Given this list of marker genes Fos, Arhgdib, Crip2, Mylk (NCBI Gene Id 68242), Cav2, Tk1, Syt10, H2bc23, Dgka, Arhgap9, Atp1a2, Man1a, Cd93, Gm22883, Nanp, Aass, Zfp970, Fgfbp1, Swt1, Esam, Trbj2-1, Cpt1a, Chd5, Slc30a1, Npr3, Pag1, Cavin2, Fes, A930012L18Rik (RIKEN cDNA A930012L18 gene), Cep290, Cd300e, Gja5, Cdca3, Tmem150a, Rbbp4, Aplnr, Tbx5, Ankra2, Tln1, Gimap6, Tmem25, Arhgap6, Arap3, Elovl4, Itga4, Slc12a4, Alox12, Hspa1b, Gja1, Svep1, Rbm3, Cadps, Rest, Gm4609, Slamf7, Adam15, Cldn18, Ace2, Casp1, Spred3, Slamf1, Ttc39c, Mab21l4, Rtp3, Pik3c2g, Dll3, 1500004A13Rik, Lamb2, Cyth4 (NCBI Gene Id 72318), Trav6n-6, Sfxn3, Cacna2d2, Gm11787, Zcchc24, Pla2r1, Zik1, Panx1, Atp8a2, Adra1a, Cd27, Trgj2, H2-T24, Gm10687, Gm3005, Sypl1, Stmp1 (NCBI Gene Id 67705), Hadh, Osbpl5, Pde5a, Eldr, Srpx2, Cnpy1, Hmcn1, Pi4k2b, Gm11651, Scube2, Col4a3, Gm12250, ENSMUSG00000122616, Gm22520, Gm3364, 4930403O15Rik, Mir378d, Efcc1, Ppm1e, Eps8l1 (EPS8-like 1), Pde3a, Acoxl, Kif1c, Ntng2, Foxa1, Fgf7, Slc2a3, Fgf12, Pax5, Tubb4a, Mmrn2, Inpp5k, Traf4, Hkdc1, Ptgfr, Maco1, Ccar1, Maml2, Abhd1, Rnf157, Slurp1, Id4, Ehd2, Zfp809, Fez2, Ago4, Cntln, Txk, Cnn2, Tmem116, Il4ra (interleukin 4 receptor, alpha), Upk1b, Tmt1a3, Ms4a6c, Hbb-bt, Fam162b, Pld2, Med9os, Ephb4, Lef1, Rasgrp2, Ephx1, Phldb2, Plxdc2, Snord16a, Tnfaip8l1, Sorbs3, 2610028H24Rik, Slc9a4, Itgax, Cecr2, Nat8f6, Pxdc1, Dhdh, Gprin3, Ptprc, Adamts1, Radx, Cbx3-ps6, Ptprb, Myo1d, Gm15675, Hecw2, Ahr, Clba1, Anks1, Rassf8, H4c16, Slamf6, Scn3a, Tmem204, Cxxc4, Fndc10 (fibronectin type III domain containing 10), Klrb1b, Esco2, Clec4a1, Trbj1-2, Angptl2, Hilpda, Il17re, Shd, Rhoj, Fbln5, Pagr1a, Trpc6, Huwe1, Sri, Cxcr2, Ctso, Blk, Epha1, Pcolce, Ccnd3, Arhgap30, Yap1, Aldh2, Snhg4, Csf1r, Ddr2, Irf8, Dock2, Drd2, Pard6b, Tob1, Gata3, Ushbp1, Actl6b, Cd84, Homer2, Wnk3, Gm10566, Prodh, Scimp, Spi1, Ube2s, Gm23247, Cd80, Tcim, Lxn, Gm3298, Gm1968 (NCBI Gene Id 328657), Scnn1b, Hlx, Itgb1bp2, Rgs18, Cer1, Mettl24, C1qtnf2, Sptbn1, Cyp4f15, Il7r, Tagln, Lamb1, Phospho1, Stmn3, 5430416N02Rik, Rasal3, P2ry14, Fam114a1, Ift57, Ppa1, Ifitm3, Rasl12, Nexn, Kank4, Edn1, Prkci, Myo10, Cmpk2, Poglut3, Ostf1, Mitf (NCBI Gene Id 17342), Epas1, Rftn2, Mt2, Fryl, Gm7551, Gm23406, Arhgap8, Mill2 (NCBI Gene Id 243864), Wls, Tmem200b (transmembrane protein 200B), Stab1, Tspyl4, Cacnb4, Flrt1, Fen1, Gulp1, Ager, Aqp4 (aquaporin 4), Amotl2, Mcm8, Nqo2 (NCBI Gene Id 18105), Arhgap27os3, Abca9, Adam22, Faf1, Syngap1 (synaptic Ras GTPase activating protein 1 homolog (rat)), Slc16a9, Mir181a-1hg, Vav1, Gm336, Dipk2b, Itpkb, Tcf7, Ar, Gm10258, Nrgn, Rnase4, Itpripl2, Acss1, Atp2b2, Swap70, Pclaf, Tbx2, Rgcc, Cavin1, Pon2, Stambpl1, Mertk, Agtpbp1, Iigp1c, Rnasel, Gbp3, 4930522L14Rik, Elmod2, Arhgef26, Crlf3, Fpr1, Plscr3, Myl12b, Dram1, Rrm2, Ctla2b, Creg1, Rnf13, Kcnj13, Cacna2d1, 2610020C07Rik, Tnfsf13b, Rnf125, Hid1, Cyth3, Clic4, Gsn, Lmtk3, Reck, Rbms2, Tcf19, Dab2, Rgs10, Tnfrsf14, Sema3f, Atp13a4, Gm14634 (predicted gene 14634), Cpped1 (NCBI Gene Id 223978), Traj40, Mpp3, Rgs7, H2bc12, Trbj1-1, Prkd2, Npc1 (NPC intracellular cholesterol transporter 1), Gm10417, Zfp953, Eloc, Myh7, Kctd11, Magi3 (membrane associated guanylate kinase, WW and PDZ domain containing 3), Stxbp5l, Msrb3, Tubgcp3, Cytip, Cdc42ep3, Hcls1, Slc39a8, Napsa, Sirpb1c, Map2, Ammecr1, Plk5, Atp8b4, Gm23258, Arl4d, Gm11110, Igsf9, Cd34 (NCBI Gene Id 98592), Tanc2, Slc23a2 (NCBI Gene Id 99086), Kcnj15, Col4a4, Tlcd2 (NCBI Gene Id 69891), Il6st, Havcr2, Nod1 (NCBI Gene Id 232000), Igfbp2, Trp53, Mdga2, Fkbp3, Zfp831, Cbx3, Ttc23, Gm26236, Lamb3, Apobec1, Gm6055, Anp32e, Slc4a5, Pik3r5, Cox5a, Sema3c, S100a10, Cit, Ttbk1, Sntb1, 9930111J21Rik1, Olfml3, Mir142hg, Notch2, Adamtsl3, Ankrd44, Traj30, Cdc42ep2, Camk2b, Gm26408, Cd3e, Kdr, Gm10400, Plaur, Gck, Aqp1, Lhfpl5, Gm3257, Nt5c3b, Prr5l, Arid5b, Clec4a3, Vsig2, Pals1, Pdgfb, B230217C12Rik, Traj29, Cd22, Acvrl1, Kif13a, Hykk, Ndufa4l2, Rap1b, Hopx, Plscr1, Tspan3, Fcrl1, Vamp5, Sh2d1b1, Higd1b (NCBI Gene Id 75689), Gm24666, Ms4a6b, Zcchc18, Coro2a, Slfnlnc (NCBI Gene Id 217016), Itga2, Synm, Hdac7, Gbp4, Zmym3, Antxr2, Kyat3, Rab29, Lrrk1, Cttnbp2nl (NCBI Gene Id 99792), Kif15, Gbp2, Phf11d, Lmnb2, Sox1, Popdc3, Prmt3, Sirpd, Gngt2, Akna, Rnf128, Itk, Mreg, H6pd, Kcnh8, Rdh10, Aldh5a1, Mgat4a, Etv5, Gprc5a (G protein-coupled receptor, family C, group 5, member A), St6galnac3, Glrb, Anxa3, Mir99ahg, Cpne8, Birc3, Fmnl1, Mypopos, Ski, Gsap (NCBI Gene Id 212167), Cd52, Adgra2, Tead4, Samd4, Glmn, Krt79, Septin4, Adap2, Nherf2 (NCBI Gene Id 76520), Gja4, Stx1b, Tmed5, Sh2d3c, Bvht, Pltp, Oas1g, Adgrl3 (adhesion G protein-coupled receptor L3), Mpeg1 (NCBI Gene Id 671359), Csf2ra, Pcdhb16, Angpt1, S100a8, Asf1b, Acer2, Qki, Scnn1g, Ifi30, Cand2, Traj22, Sft2d2, Abhd8, Prickle1, Jak1, Ms4a1, Cep83os, Hat1, Stk4, Vat1, Vipr1, Sgms1, Xdh, Cd226, 1700102H20Rik, Sv2a, Hyal2, Mmp15, Polq, Lpar6, Rras, Csrnp2, Amer2, Jph1, Atf7, Bcl9l, Agbl4, Soat1 (NCBI Gene Id 98715), Gdnf, Ch25h, Eng, Prkcq, C6, Ptprt, Nynrin, Phlda1, Gm23792, Fxyd5, Gstk1, Syde1, Gbp5, Gpx1, Adamtsl1, Gramd2a, Dsc2, Traj9, Mfsd4b3-ps, Ppbp, Deptor, 2010310C07Rik, Carmn, Sdk1, Map1b, Or2v1, Lrp4, Morrbid, Icam2, Ripor1, Rims3, Haus5, Cyp27a1, Slco4a1, Cdc42ep1, Slc7a3, Rac2, Pld4, Naalad2, Gm12474, Ltbp4, Lyl1, Shisa5, Hoxa2, Tmem156, Hebp1, Cdh4 (cadherin 4), Mir5104, Aff1, Atp6v1c2, Thsd1, Sash3, Pakap, Clip3, Slc2a12, Csrp1, Slc25a24, C2cd4b, Mast2, Gm10521, Col6a3, Pik3r3, Neto2, Slc52a3, Thbs4, Selenoh, Clstn3, Ccl19-ps5, Sh3tc2, Rexo5, Sox17, Smim3, Haspin, 4930562F07Rik, Mef2c, Alox5ap, Gm53567, Myg1, Camk1d, Mcemp1, Cd96, Timp2, Tmcc3, Traj37 (T cell receptor alpha joining 37), Stard13, Rassf5, Lats2, Stk17b, Slc43a3, Pola2 (NCBI Gene Id 18969), Fbxo30, Flt3l, Adgrl2, Pik3r6, Tlr2, Serpine2, Cpne5, Tmem243, Mt1, Gpr137b, Tns1 (NCBI Gene Id 98418), Pdzd2, Tdp2, AV099323, Gm3760, Cldn1, Arl6, Ipcef1, Slc22a3, Casp8ap2, 2610318N02Rik (RIKEN cDNA 2610318N02 gene), Fmo1, Tns2, Hcn1, Trav9-2, Traj28, Ppm1f, Hspa12b, Mme, Prcp (prolylcarboxypeptidase (angiotensinase C)), Mrgpra2a, Aspa, Plscr4, Cd37, Ldaf1, Tyrobp, Col4a5, Hoxa5, E2f3, Gm13816, Lrrc24, Sox7, Carmil3, Spats2, Mir344e (microRNA 344e), Tlr3, D17H6S56E-5, Cmah, Crim1, 1810010H24Rik, Tas2r143, Kctd13, 9030404E10Rik (RIKEN cDNA 9030404E10 gene), Kctd12b, Hspg2, 2410004I01Rik, Foxf1, Slc36a2, Itgb6, Pcolce2, Septin1, Lifr, Lcp2, Il33, Ifnar2, Sgk1, Cd24a, 9530026P05Rik, Mal2, Rab7b, Gm23101 (NCBI Gene Id 115489644), Gm3317, Fads3, Gm23692, Ncf2, Tmem71, Tmem145, Gm8281, Hdc, Extl2, Des, Map1a, Sytl5, Col4a1, Col6a2 (NCBI Gene Id 216121), Resf1, Nudt5, Adhfe1, Pik3cd, Klhl5, Ppil1, Mtbp, Treml2, Smpd3, Unc80, Akap17b (NCBI Gene Id 338351), Elfn1, Cd4, Sox18, Adrb1, Rsu1, Gpr18, Tnfsf13, Trim65, Sema3g, Phaf1, Clec9a, 2010016I18Rik, Vipr2, Pla2g15, Dcxr, Itgb2, Ccnf, Cep78, Serpinh1, Hspb1, Rarg, Cep97, Cxcl14, Ikzf1, B3gnt5, Dock9, Gm23138, Tmpo, Dlc1, Ggt7, Ly9, Rhog, Hacd1, Epha7, Serpinb1a, Dock4, Pkhd1l1, Stap1, Gm13034, Cysltr1, Fkbp7 (NCBI Gene Id 14231), Lrrc32, Snai2, Tspan32, Serpini1, Oip5, Angpt2 (NCBI Gene Id 11601), Smim15, Serpinb10, Grap2, Prdm5, Plbd1, Htra1, Fmr1, S100a13, Plpp1, Arhgef18, Rbmx2, Dusp1, Gm25788, Lama3, Epha2, 9630013D21Rik, Klc1 (kinesin light chain 1), Reps2 (NCBI Gene Id 237196), Tmem100, Inpp4b, Syngr3, 2610027K06Rik, Slc5a12, Gm22023, Dock8 (dedicator of cytokinesis 8), Wwc2, H2ac21, Rin2, Ahcyl1, Ccl5, Traj12, P2ry6, Gm3095, Nrros, Nkg7, Adamtsl5, Gm6340, AA986860, Eps8l2, Nostrin, Tfec, Itpr2, Steap3, Gsdmd, Gimap1, Spaca6, Exosc2, Sh3tc1, Ncf1, Igfbp6, Lmntd1, Rspo1, Diaph1, Vegfa, Adamts8, Trpm6, Alas1, Mvp, Gdpd3, Mtfr2, Ttc12, Elovl2, Slfn3, Cpn1, Il12rb2, Suv39h1, Ksr2, Gpr132, Rfc2, Dach1, Cd151, Pdlim2, Bcl2a1a, Adam19, Serpinb9, Dnajc6, Alox5, Slc22a17, Hba-a1, Acer3, Arhgap28, Ccbe1, Lyn, Pacsin1, Ces2g, Gnasas1, Fermt3, Pla2g1b, Erg, Atm, Mcl1, Sh2d4a, Arhgef5, Prr36, Zcwpw1 (zinc finger, CW type with PWWP domain 1), Gm2237, Vamp8, Gnl3l, F2r, Tmbim1, Prdx2, Cdh5, Zfp521, Myo1c, Rabggtb, Gimap9, Kif5a, Bin2, Fabp1, Elf5, Rnf43 (NCBI Gene Id 207742), Tmem144, Mybl2, Hdac6, Stxbp3, Gimap3, Cip2a (NCBI Gene Id 224171), Eif1b, Adcy4, Colec12, Lpin2 (lipin 2), Gask1a, Ddx25, Filip1, Cdh22, Smurf2, Bmx, Gm17473, Pilrb1, Diaph2, Mpp1, Fermt2, Ehd1, Emp2, Mfge8, Mfap3l, Traj39, Kcnj2, Acot9 (NCBI Gene Id 97583), Traj18, Abca3, Vegfd, Fhl1, Ccr7, Cpne3, Ctnnd1, Gzma, Klhl6, Stard9, Npr1, Gimap4, Smo, Stxbp6, Ets1, Gimap7, Pkn3, Cd6, Acap1, Flt4, Cd2, Gimap8 (GTPase, IMAP family member 8), Pde1c, Rasip1, Gvin1, Mthfd1l (methylenetetrahydrofolate dehydrogenase (NADP+ dependent) 1-like), Snap23 (NCBI Gene Id 98773), Tfpi, Ror2, E2f2, Tnxb, Pitpnm3, Fgfr4, Calhm5, Mir218-1, Id3, Prkch, Aqp5, Ppic, Slc13a4, Fbxo47, Grk5, Serpinb6b, Sstr4, Hbb-bs, Wnt2, Rad51c, Dync2h1, Sh3gl2, Adgre4, Cd8b1, Parp1, Mob3a, Ccdc88a, Tbkbp1, 4933409K07Rik, Ttyh2, Cmtm6, Cplx2, Tlr5, Cd3g, Arap2, Gask1b, Traj44, Lgals9, Nalcn, Vav3, Ctsw, Adh1, Me2, Gvin-ps2, Tlr4, Spry4, mt-Co1, Zfp697, Zfp367, Pgap1, Sema7a, Skp2, Scarf2, Slc10a6, Pex5l, Pole2, Irag2, Cacna1a, Zfp57, Ankrd34b, Gm19445, Gm23431 (predicted gene, 23431), P2ry10, Il2rg, Adamtsl4, Gpr183, Trbc1, Gm10824, Arpc5l, Gpr4, Col4a2, Lama4, Cilk1, Ces1e, Ifngr1, Ppt1, Arl6ip6, St8sia4, Clic5, Arhgap15, Nkd2, Dtymk, Snord123, Map4k3, Npas4, Plcb2, Spast, Parp14 (NCBI Gene Id 72239), Gstt2, Selplg, Rapgef4, Irak2, Il27ra, Klf4, Clec1a, Ackr3, Megf9, Cftr, Taok3, Syt7, Cd19, Rnps1, Cyba (NCBI Gene Id 13057), Filip1l, Enox1, Smad7, Cyb561a3, Cers2, Epb41l2, Tmem176a, Mxra8, ENSMUSG00000134718, Heg1, 9230117E06Rik, Ltc4s, Pwwp2b, Timeless, Scarna17, Prkg2, Pdik1l, Slco4c1, Plagl1, Phf11b, Dennd1c, Sorbs2, Rfc3, Pcdh17, Npnt, Icam1, Susd4, Cst8, Tnfsf10, Adgrl1, Mir145a, Sult1a1, Mgll, Nckap1l (NCK associated protein 1 like), Bmper, Naaa, Wwp1, Akr1c14, Gm2897, Gm26425, Ramp2, Cpm, Oplah, Chic1, Abhd4 (NCBI Gene Id 68688), Ifi203, Micu3, Mir690, Ark2c, Mrc2, Car4, Shmt2, Cav1, Trac, Gstm2-ps1, Car14, Jcad, Gvin-ps7, Lpcat1, Nrn1, Kcnk6, Erbb2, Rnase6, Pianp, Zfp992, Nrxn2, Spon1, Alyref, Gm22459, Wfdc1, Rbbp8, Tbx4, Chrnb1, Macroh2a2, Hhip, Sp100, Ogdhl, Pnpla7, S1pr2, Chst15, Shroom4 (NCBI Gene Id 208431), Rbm46, Neto1, Gab3, Spry1, Tmem171, Plac9, Smarca4, Zfp595, Elovl1, Gm8159, Gm8237, Tjp1, Adgrf5, Gm3264, Plxna2, AW112010, Zfp982, Dnase1l1 (NCBI Gene Id 69537), Slc8a2, AU020206, Ccnd2, Tbx3, Tmod1 (tropomodulin 1), Eno2, Rbpms2, Lnx1, Arhgap29, Lilra6, Lrat, Slc15a1, Ecscr, Gstt1, Zfp872, Stx11, Ear1, Adcy8 (NCBI Gene Id 11514), Laptm5, Btla, Zyx, Cyp2d22, Slc49a3, Klf2, Sptb, Trp53bp2, Gm25290, Fbxo16, Slc7a10, Cyp2j9, Scarf1, Slc66a3, Aatk, Unc13a, Ppp1r16b, Snx20, Arhgap45, Cyb5a, Hsd3b2, Sptlc2, Siglecf, S100a9, Parvg, Tram2, Flna, Myct1, Slc7a7, Mafk, Irgm2, Necab1, Zbtb4, Bmp4, Magi2, Dgcr8, Slfn2, Vwa5a, Themis, Bicdl1, Cd5, Gpam, C2, Rmdn2, Ilf2, Ms4a8a, Psmb10, Ackr2, Cd48, Ift27, Iigp1, BC028528, Gm26175, Mid2, Vstm4 (V-set and transmembrane domain containing 4), 4632404H12Rik, Notch4, Arhgef15, Themis2, Stat6, I830077J02Rik, BE692007, Slc6a5, Flt3, Rnf144b, Gapt (NCBI Gene Id 238875), Gnao1, Bub1, 2310001H17Rik, Tbxas1, Gm19872, Hfe, Prdm1, C030013C21Rik, Gm8108 (predicted gene 8108), Tas2r135, Tcn2, Mmp19, Ipo9, H2bc7, Maoa, Stk10, Gm25831, Spc24, Tacc1, Adgrg6, Ctnnbip1, Slc38a4, Dlgap3, Myzap, Zfp9, Cyp4b1, Crispld2 (NCBI Gene Id 78892), Cspg4b, Tmem150c, Slc12a5, Egfl7, Slc22a23, Psat1, Nphp4, Bhlhb9, Fstl3, Ccm2l, Efna1, Trbc2, Tent5c, Ehd4, Cd68, Wwtr1, Tcerg1l, Mamdc2, Rapgef3 (NCBI Gene Id 70104), Ptgs1, Xpnpep2, Lsp1, Tia1, Upk3b, Tnfrsf19, Cr2, Sirpb1a, F2rl1, Dpagt1, Kcnj6, Spata31f1a, Slc25a45, Kif24, Hnmt, S1pr1, Clec12a, Sox5it, Itgb7, Mir223, Foxf2, Lmnb1, Luzp1, Traj21, Myo1g, Btk, Elk4, Cebpb, Rbm24, Cd300ld, 9230114K14Rik, Phxr4, Paqr8, Ccdc136, Rpa3, Rai14, Gbp10, Pttg1ip, Myo5a, Plekhd1, Xaf1, H2-Ea, Rnf39, Tcp11l1, Clec7a, Adgre5, Plvap, Aldh6a1, Apool, Lrrc9, Gm614, Cxcr5, Abca17, Olfml1, Smpdl3a, Tgfbr2, Itga1, Ccl19-ps2, Naa40, Rigi, Mctp1, Akap13, Bmp6, Msh2, Pde1a, Csgalnact2, Gpihbp1, Ercc6l, Ablim3, Tie1, Tcf21, Rftn1, Nfkb1, Wdr90, Shank3, Cyp4v3, Slco2a1, Mmp28, Traj35, Ablim1, Erh, Rgs9, Aph1c, Fgfr3, Amer3, Shh, Cdhr1, Myo1f, Nfam1, Apbb1ip, Tmem47, Slc9a7, Clmn, Tigd3, Ptgis, Prdm8 (NCBI Gene Id 77630), Adgrl4, Kctd21, Trit1, Sec61a2, Cldn5, Dennd3, Cabp1, Lcorl, Kcnab3, E2f1, Sirpb1b, Gdap1, Sh3rf2, Sp110, B3gat1, Cenpc1, Ddx43, Meis1, She, Brsk1, Xrcc3, Eml5, Ly86, Gpr33, Rin3, Acot2, Krt23, Ccdc9b, Tlr8, Wdr62, Map4k1, Ccn1, Podxl, Slc6a14, Scgb1c1, Gm15987, Usp49, Nefh, S1pr3 (sphingosine-1-phosphate receptor 3), Clec2d, Cflar, Ltb, Pcdh1, Dlg4 (discs large MAGUK scaffold protein 4), Bcl7a, Matn4, Mgl2, Mad2l2, Evi2a, Adgrv1, Pcsk6, Cnr2, Nes, Gpr182, Hyal1, Cd8a, Tcf7l2, Vsir (NCBI Gene Id 74048), Copz2, G0s2, Clic3, Rrad, Popdc2, Kctd10, Nbeal1, Sla, Dcx, Traf1, Rhbdf2, Dhrs3, Ggcx, Arhgap33, Nckap5, Gstm5, Gm24620, Traf5, Bst1, Msn, Syt11, Mir680-1, Nfe2l2, Clec2i, Ccdc34, Syn2, Itgb3bp, Hpf1, Efnb2, Tmbim6, Arhgef6, Tspan11, Dram2, Vegfc, Celf6, Zfp932, Nabp1, Wif1, Tmod3, Deup1, P2ry12, Gp9, Ndc1, Als2cl, Mir23a, Pear1, Efnb1 (ephrin B1), Klf15, Ndst1, Cryab, Lilra5, Meox2, Arhgap42, Tgm2, Fzd4, Cemip2, Gm23579, Abi3, Tbx1, Was, Nipal1, Actr3b, Mlc1, Chek2, Pop1, Pcdhb19, Gstt3, Smt3h2-ps, St8sia5, Klf6, Tespa1, Daam2, Bnc2, Tasl, Rbbp7, Niban1, Ctsc, Aldoc, Trim21, Calcrl, 6530402F18Rik, Aox1, Mustn1, Mboat1, Rad51ap1, Slamf9, Ngp, Haus6, Retnlg, Rtkn2, Platr21, Ebf1, Ctxn1, Rgs6, Cd180, Rab38, Ctnna1, Trim28, Rhob, Cenpp, Nat8f3, Abhd14b, Tfrc, Ddit4, Ldhb, Cast, Adgre1, Cmtm3, Emcn, Marveld1, Frmpd4, Cybb, Sh2b3, Pilra, Lpar3, Vgll3, Hsd17b11, Ms4a4b, Eri2, Ctse (NCBI Gene Id 319365), Ncs1, Abca6, Platr22, Krt80, Ccdc125, Siglech, Ace, Fzd7, Adora2b, Ptpru, Celf3, Brca1, Notch3, Rap1a, Gm15883 (NCBI Gene Id 102632321), Ppp1r14a, Pafah1b3, Fzd3, Snap25, Mark1, Grem2, Sh3bp5, Pdpn, Slfn9, Egflam, Efcab7, Lipa, Aldh3a1, Iah1, P2rx4, Septin3, C1qtnf7, Pgk1, Hbegf, Trip10, Flvcr2, Fbxo48, Ston1, Hvcn1, Rabac1, Hpse2, Purg, Rassf3, Ifitm1, Col6a1, Kcnip3, Gpr141b, Fgd5, Pgbd5, Crtac1, Zswim5, Taf1d, Mcc, Disp2, H2-DMa, Lims2, Sema3b, Gm9917, Rasgrp1, Kcnq2, Olr1, Mapk4, Ddias, mt-Tq, Zfhx2, Il15 (interleukin 15), Parp3, Pi15, Prss12, Mcam, Stard8, Gm23947, Slc24a4, Dscc1, St3gal1, Klrd1, Lrrc49 (NCBI Gene Id 235429), Sell, Marchf2, Arhgap32, Camk2n2, Tnk2, Rarres2, Frat1 (NCBI Gene Id 14296), Pcdh18 (NCBI Gene Id 99940, protocadherin 18), Bhlhe41, Prx, B230369F24Rik, 2610203C22Rik, Slfn1, Ccr2, Tinag, Cd7, Grap, Lat, Fgr, Fblim1, Inf2, Pde3b, Gata2, D430041D05Rik, Nup93, Mecom, Ptpre, Miat, Tmem154 (transmembrane protein 154), Tnfsf15, Tenm4, 4933412E12Rik, Cd209a, Il18rap, Tnfrsf22, Ptger2, Itm2a, Tmem139, Traj19, Kifc3, Sash1, Unc13d, Gbp9 (NCBI Gene Id 236573), Chst3, Gbp7, Inpp5d, Spata31f1b, Kank3, Sipa1, Clec14a, Bsn, Rnf227, Nop56, Prdx6, Il18, Trim16, Cep162, Cxcr6, Gm7097, Gm15222, Mtmr10, Far2, Anapc15, Chia1 (NCBI Gene Id 81600), Kynu, Bank1, Wdfy4, Hes1, 2700099C18Rik, Cass4, Nelfcd, Fzd5, Slc44a2, Rasgrp3, Tmem63c, Cgnl1, Serinc2, Plin3, Adrb2, Gm13840, Sema6a, Tpp1, Rnf144a, Plac8, Tnfrsf13b, Slc7a5, Srrm2, Syn1, Utrn, Sccpdh, Lrp2, Fhl2, Mir28c, Inafm2, Dek, Nalf1, Dysf, Akap5, Trbj1-4, Trp73, Dusp3, 4930556M19Rik, Zfp667, Pdk2, Maob, Ifi204, Tspan7, Il34, Veph1, Adgrg2, Pxmp2, Garre1, Gm5796, Elk3, Etl4, Ccnd1 (cyclin D1), Myadm, Hmgcll1, Zfp991, Il2rb, Ier3, Tinagl1, Mocs1, Dusp6, Zfp984, Trbd2, Il18r1, Ttc6, Prss23os, Sfta2, A330023F24Rik, Serpina3c, Numb, Thbs3, F830016B08Rik, Cyyr1, Samd5 (sterile alpha motif domain containing 5), Il16, Arhgef12 (Rho guanine nucleotide exchange factor 12), Pex7, Espl1, Gm23864, Gm10287, Gm25135, Usp51, Itgal, Car2, Trbv1, Sdc4, Cmklr1, Traf3ip3, Gtf2ird1, Abcc3, Gpr146, Liph, Kmo, Fyb1, Mastl, Tnfaip2, Gucy1b1, Cd244a, Ccdc159, Arhgap25, Slfn5, Tcp11l2, Smad6, Ahnak, Spn, Cntnap1, Slc26a2, Ikzf3, Slc6a4, Bmpr2, Fbxo5, Gm15991, Hck, Tuba1c, Uchl5, Phactr2, Zfp366, Bach2, Ros1, AB124611, 4933431E20Rik, Tubg2, Cxcl16, Fendrr, Gimap5 (NCBI Gene Id 319541), Mphosph9, Pals2, Pacsin2, Cdca7, Rfwd3, Gpc3, Sgpp2, 1700086L19Rik, Glb1l3, Adk, Aldh3b1, Eogt (EGF domain specific O-linked N-acetylglucosamine transferase), Caskin2, Cd69, Iglc3, Frmd5, Trbd1, F7, Dpp4, 5830428M24Rik, Mocos, B430203G13Rik, Usp1, Alas2, Fam135a, Cfap300 (cilia and flagella associated protein 300), Ly6c1, Ccdc85a, Jag1, A130050O07Rik, Fmo5, Mirlet7a-1, Thbd, Nid1, Tecrl, Add2, Gng11, Acot1, 4930486L24Rik, Fbxo45, Rnf168, Vsnl1, Bex1, Scube1, Tlr7, Gemin6, Wdr35, Gipc2, Fbxl7, Cacng4, Slc6a2, Flt1, Gm24622, Irf5, Ednrb, Raver2, Afap1l1 (NCBI Gene Id 225605), Plscr2, Tbx3os1, Mns1, Auts2 (NCBI Gene Id 72597), Cd28, Efemp1, Ajuba, Npw, Tagap, Grb14, Ephx4, Igfbp5 (NCBI Gene Id 98676), Fhod1, Il10ra, Prdm6, 1700018A04Rik, Eif2s3x, Cd40, Papss2, Fas, ENSMUSG00000094514, Slc7a1, Tgfb1i1, Pcdh12, Smyd2, Ldb2, Entpd1, Smad3, Plxnd1, Hacd4, Card11 (NCBI Gene Id 69728), Rcsd1, Plxna1, Gstp3, Klra2, Tmem163, Scel, Rbpjl, Nat8f7, Ciita, Il17rd, Irak4, Hmga2-ps1, Nol4, Zfp41, Sorl1 (sortilin-related receptor, LDLR class A repeats-containing), Arrb1, Anxa5, Gm24046, Lcp1, Vcl, Lpxn, Snrk, Nanos1, Ctla2a, Itgb5, Dnph1, Rhbdf1, H2bc18, Zfp36l1, Rbm47, Robo4, Bmp3, Traj13, Mcm10, Dynlt1b, Mbnl1, Csf3r, Ndnf, Hsd11b1, 9330159F19Rik, Pdgfd (NCBI Gene Id 71785), Samhd1, Tmem140, Tnfaip8l2, Cfap69, 4930523C07Rik, Zfas1, Zfp946, Fcmr, Abcb1a, Ece1, Cyp2j6, Tek, Pten, Pecam1, here is a description of the gene set: Rb1<F/F>; Rbl1<-/->; Pten<F/F>; Trp53<F/F> mice were generated by breeding Trp53<F/F>; Pten<F/F> mice with Rb1<F/F>, Rbl1<-/-> mice. studied in species Mus musculus Genes differentially regulated in K5-QKO SCLC tumors from Rb1<F/F>;Rbl1<-/->;Pten<F/F>;Trp53<F/F> mice versus normal lung tissue. from publication Lázaro S, Pérez-Crespo M, Lorz C, Bernardini A, Oteo M, Enguita AB, Romero E, Hernández P, Tomás L, Morcillo MÁ, Paramio JM, Santos M (PMID 31611390) Mouse Gene Set: LAZARO_GENETIC_MOUSE_MODEL_HIGH_GRADE_SMALL_CELL_NEUROENDOCRINE_LUNG_CARCINOMA_DN